Given this list of marker genes H3C11, H3C2 (H3 clustered histone 2), H2AC16, H2AC7 (H2A clustered histone 7), H2BC14, ABTB2, H2BC6, H2BC15, GBX2, H2AC8, H2AC11, ZNF710, H3C8, H2BC3, SEZ6, H1-1, PHACTR3 (phosphatase and actin regulator 3), H3C7, H3C3, H3C4, H2AC12, H2BC1, H1-2, H2BC4, H3C6, H2AC25, H2AC20, H2BC11, H1-4, ZBTB9, H2AC15, H2BC9, CYBC1, TMTC4, DSCAM, UBE2C, H1-5, H2BC26, H2AC13, H2BC8, H2BC21, NOTCH4, H2BC5, H2BC7, H2AC21, H3C1, PCGF1, H3C10, H2AC1, H2AC4, H3-4, H2AC17, H2BC12, H1-3, H2BC13, H3C12, PRRC2C (NCBI Gene Id 23215), CDK15, H1-6, H2AC6, H4C13, H2BC17, PLXNB1, H2AC14, TCF21, H4C1, here is a description of the gene set: Genes having at least one occurrence of the highly conserved motif M120 KRCTCNNNNMANAGC in the regions spanning 4 kb centered on their transcription starting sites. The motif does not match any known transcription factor binding site. from publication Xie X, Lu J, Kulbokas EJ, Golub TR, Mootha V, Lindblad-Toh K, Lander ES, Kellis M (PMID 15735639) Comprehensive identification of all functional elements encoded in the human genome is a fundamental need in biomedical research. Here, we present a comparative analysis of the human, mouse, rat and dog genomes to create a systematic catalogue of common regulatory motifs in promoters and 3' untranslated regions (3' UTRs). The promoter analysis yields 174 candidate motifs, including most previously known transcription-factor binding sites and 105 new motifs. The 3'-UTR analysis yields 106 motifs likely to be involved in post-transcriptional regulation. Nearly one-half are associated with microRNAs (miRNAs), leading to the discovery of many new miRNA genes and their likely target genes. Our results suggest that previous estimates of the number of human miRNA genes were low, and that miRNAs regulate at least 20% of human genes. The overall results provide a systematic view of gene regulation in the human, which will be refined as additional mammalian genomes become available. studied in species Homo sapiens Human Gene Set: KRCTCNNNNMANAGC_UNKNOWN